The following is a description of a gene set: species: Mus musculus Cytokines mediate cell-cell communication in the immune system and represent important therapeutic targets. A myriad of studies have highlighted their central role in immune function, yet we lack a global view of the cellular responses of each immune cell type to each cytokine. To address this gap, the authors created the Immune Dictionary, a compendium of single-cell transcriptomic profiles of more than 17 immune cell types in response to each of 86 cytokines (>1,400 cytokine-cell type combinations) in mouse lymph nodes in vivo. A cytokine-centric view of the dictionary revealed that most cytokines induce highly cell-type-specific responses. For example, the inflammatory cytokine interleukin-1β induces distinct gene programmes in almost every cell type. A cell-type-centric view of the dictionary identified more than 66 cytokine-driven cellular polarization states across immune cell types, including previously uncharacterized states such as an interleukin-18-induced polyfunctional natural killer cell state. Genes negatively differentially expressed in cell type: CD8+ T cell upon treatment with cytokine: IL-17A in mouse lymph nodes in vivo. Mouse Gene Set: CUI_T_CELL_CD8_IL17A_RESPONSE_DN from publication Cui A, Huang T, Li S, Ma A, Pérez JL, Sander C, Keskin DB, Wu CJ, Fraenkel E, Hacohen N (PMID 38057668), and this is the list of marker genes: Hspa1a, Klf6, Hspa1b, Fos, Cd74, Zfp36l2